Given this list of marker genes CASQ1, FGF13 (NCBI Gene Id 730528), STAC, STIMATE, HAP1, GALR2, LRRC26, CTSS, ACTN2, EDN1 (endothelin 1), LRRC55, HTT, JPH2, NIPSNAP2, STAC3, STIM2, LRRC52, EDNRA, LRRC38, CACNB3, STAC2, TMSB4X, STIM1, ATPSCKMT, CRACR2A, ASPH, SCN1B, GAL, here is a description of the gene set: studied in species Homo sapiens Any process that activates or increases the frequency, rate or extent of cation channel activity. Human Gene Set: GOBP_POSITIVE_REGULATION_OF_CATION_CHANNEL_ACTIVITY